Given this list of marker genes Erbb2, Adam17, Adam10, Erbb4, Hbegf (NCBI Gene Id 225370), Bace1, Nrg1, Ereg, here is a description of the gene set: Mouse Gene Set: GOBP_ERBB2_ERBB4_SIGNALING_PATHWAY species: Mus musculus The series of molecular signals initiated by binding of a ligand to a ERBB4 receptor on the surface of a cell, followed by transmission of the signal by a heterodimeric complex of ERBB2 and ERBB4. ERBB2, which does not bind any known ligand, is activated through formation of a heterodimer with another ligand-activated ERBB family member such as ERBB4.